The following is a description of a gene set: Mouse Gene Set: GOBP_DETECTION_OF_OTHER_ORGANISM The series of events in which a stimulus from another organism is received and converted into a molecular signal. studied in species Mus musculus, and this is the list of marker genes: Nod1, Cd209b, Naip2 (NCBI Gene Id 17948), Tlr1, Pglyrp3, Tlr2, Naip1, Nlrc4 (NLR family, CARD domain containing 4), Pglyrp1, Tlr6, Pglyrp2, Nod2, Parg, Naip6, Naip5, Clec4n, Ssc5d (NCBI Gene Id 269855), Pglyrp4, Clec7a